Given this list of marker genes THBS1, MPRIP, AMIGO2, LRP8, NAP1L1, SLC20A1, here is a description of the gene set: Genes down-regulated early in HMEC cells (mammary epithelium) during acinar development in vitro. Nonmalignant human mammary epithelial cells (HMEC) seeded in laminin-rich extracellular matrix (lrECM) form polarized acini and, in doing so, transit from a disorganized proliferating state to an organized growth-arrested state. We hypothesized that the gene expression pattern of organized and growth-arrested HMECs would share similarities with breast tumors with good prognoses. Using Affymetrix HG-U133A microarrays, we analyzed the expression of 22,283 gene transcripts in 184 (finite life span) and HMT3522 S1 (immortal nonmalignant) HMECs on successive days after seeding in a lrECM assay. Both HMECs underwent growth arrest in G0-G1 and differentiated into polarized acini between days 5 and 7. We identified gene expression changes with the same temporal pattern in both lines and examined the expression of these genes in a previously published panel of microarray data for 295 breast cancer samples. We show that genes that are significantly lower in the organized, growth-arrested HMEC than in their proliferating counterparts can be used to classify breast cancer patients into poor and good prognosis groups with high accuracy. This study represents a novel unsupervised approach to identifying breast cancer markers that may be of use clinically. Human Gene Set: FOURNIER_ACINAR_DEVELOPMENT_EARLY_DN from publication Fournier MV, Martin KJ, Kenny PA, Xhaja K, Bosch I, Yaswen P, Bissell MJ (PMID 16849555) species: Homo sapiens